The following is a description of a gene set: studied in species Homo sapiens Enables the transfer of icosanoids from one side of a membrane to the other. Human Gene Set: GOMF_ICOSANOID_TRANSMEMBRANE_TRANSPORTER_ACTIVITY, and this is the list of marker genes: SLC22A2, SLCO2A1, SLC22A7, SLC22A6, SLCO1B1, SLCO3A1, SLC22A11, SLC22A1, SLCO4A1 (solute carrier organic anion transporter family member 4A1), ABCC4, ABCC3, SLCO2B1, SLC22A8